Given this list of marker genes ZNF367, SKI, HSD17B4, MED21, FASLG, CLDN8, TENT5A, PBRM1, BTG2, GID4, JAG1, OSR1, SOS2, ADGRG2, TIAM1, ANGPTL5, MBNL3, PPP1R3A, THRB, RAD51AP1, MATN2, ANKS1B, CCL1, IL6R, VCL, PDCD4, UBR3, ZBTB41, PCSK6, KLF3, SCML2, ARL1, TGFBI, NIPAL2, CPEB3, CASKIN1, GLIS2, ARHGAP24, NTF3, LPA, RAB6D, YAP1, EPM2A, OLFM3, ATXN10, KDM1B, KCNJ10, MAP3K1, MAST4, FAM3C, ELF2, HIPK3, PAN3, SOX5, BAHD1 (bromo adjacent homology domain containing 1), CSRNP3, NFIA, FAM13A, CCL20, RP2, NPPB, PELI1, RBPJ, RASA2, RASA1, BCL11B, MPRIP, FGF18, STAT3, GPATCH2L, CHIC1, TMEM170A, NEGR1, C7, SMARCD1, ZNF704, NFIB, PDZD2, CFAP300, TIMP3, BCL7A, PRDM11, PPP1R3B, LRRC57, RMND5A, GLCCI1, EHD1, SLC30A10, SMAD7, ALX4, CLIC2, CREBRF, CUX1, NIPAL1, RASGRP1, SYT15, RALGPS2, NKIRAS1, ITCH, YOD1 (NCBI Gene Id 55432), IL12A (NCBI Gene Id 3592), PPP1R3D, SKP2, RNF103, CNBP, MCMDC2, PITX2, BCL11A, RSAD2 (radical S-adenosyl methionine domain containing 2), KRIT1, STAG2, USP15, LTV1, AKAP12, GNAQ, PLAG1, WWP1, TPRG1L, KDM7A, MEI4, UBE2D3, RECK, SPRY1 (NCBI Gene Id 91129), GATAD2B, STK38L, MALT1, GRAMD2B, EPHA4, SPRY2, RBMS3, PLEKHA1, here is a description of the gene set: Genes predicted to be targets of miRBase v22 microRNA hsa-miR-590-5p in miRDB v6.0 with MirTarget v4 prediction scores > 80 (high confidence targets). species: Homo sapiens from publication Chen Y, Wang X (PMID 31504780) Human Gene Set: MIR590_5P